The following is a description of a gene set: studied in species Mus musculus This event has been computationally inferred from an event that has been demonstrated in another species.<p>The inference is based on the homology mapping from PANTHER. Briefly, reactions for which all involved PhysicalEntities (in input, output and catalyst) have a mapped orthologue/paralogue (for complexes at least 75% of components must have a mapping) are inferred to the other species. part of: Interferon Signaling electronically inferred by orthology from the curated human pathway Reactome Pathway: Antimicrobial mechanism of IFN-stimulated genes, and this is the list of marker genes: Mapk3, Ppm1b, Gbp2, Faap100, Tubal3, Tuba3b, Trp53, Eif4a2, Oasl1, Becn1, Tubb6, Eif4a1, Map2k6, Ube2n, Hspa1l, Arih1, Uba7, Mavs, Cdk1, Tuba4a, Ilf3, Faap20, Fance, Hspa2, Ptpn2, Fancb, Fancg, Dus2, Ilf2 (NCBI Gene Id 67781), Tuba1b, Fnta, Flnb (filamin, beta), Eif4e3, Ube2e1, Tarbp2, Irf3, Tubb2b, Tubb4a, Npm1, Pde12, Tuba1a, Snca, Rigi, Cenpx, Fancc, Tuba1c, Gbp5, Mapt (microtubule-associated protein tau), Cenps, Ppp2r5a (NCBI Gene Id 226849), Ikbkb, Tubb4b, Tuba8, Ppp2r1b